Given this list of marker genes HMX1, TMEM237, PAX6, DNM1L, OPA1, PAX2, here is a description of the gene set: species: Homo sapiens Morning glory anomaly An abnormality of the optic nerve in which the optic nerve is large and funneled and displays a conical excavation of the optic disc. The optic disc appears dysplastic. Human Gene Set: HP_MORNING_GLORY_ANOMALY